The following is a description of a gene set: Genes up-pregulated by dsRNA in GRE cells (glioma; no interferon system). Human Gene Set: GEISS_RESPONSE_TO_DSRNA_UP species: Homo sapiens Double-stranded (ds) RNA, a common component of virus-infected cells, is a potent inducer of the type I interferon and other cellular genes. For identifying the full repertoire of human dsRNA-regulated genes, a cDNA microarray hybridization screening was conducted using mRNA from dsRNA-treated GRE cells. Because these cells lack all type I interferon genes, the possibility of gene induction by autocrine actions of interferon was eliminated. Our screen identified 175 dsRNA-stimulated genes (DSG) and 95 dsRNA-repressed genes. A subset of the DSGs was also induced by different inflammatory cytokines and viruses demonstrating interconnections among disparate signaling pathways. Functionally, the DSGs encode proteins involved in signaling, apoptosis, RNA synthesis, protein synthesis and processing, cell metabolism, transport, and structure. Induction of such a diverse family of genes by dsRNA has major implications in host-virus interactions and in the use of RNA(i) technology for functional ablation of specific genes. from publication Geiss G, Jin G, Guo J, Bumgarner R, Katze MG, Sen GC (PMID 11487589), and this is the list of marker genes: IFIT1, SRGN, BIRC2, ANXA1, KLF4, AFAP1, NMI, CFLAR, TFPI2, CCL4, HMGB2, SAT1, ACSL3, GCH1, CD44, XPO1, BTN3A3, PSMA3, IQGAP2, EIF2S3, NFKBIA, UBQLN1, ATF3, TNFAIP6, PLAUR, TNFAIP2, TRAF1, FGF2, SUOX, IRF1, TNFAIP3, CHN1, BNIP3, TAP1, GBP1, CCL2, IGFBP6, ELF3, ADAR